Given this list of marker genes CD160, HOMER2, HIF1AN (NCBI Gene Id 84175), MEGF8, MSRB3, KDM4A (NCBI Gene Id 9682), PPFIA2 (NCBI Gene Id 8499), TIMM22, SEC22C, USP34, GID4, HTR2C, GIGYF2, TBC1D20, RGS4, RFTN1, RASAL2, FHIP2A, ZNF107 (NCBI Gene Id 7660), SH3TC2, MCTP2, ASB6, PSD3, PLD3, CCNE1, DCUN1D3, SATB2, PARP14, CNKSR2, ZDHHC16, PTPN12, FAM53C, RNF169, PRDM1, ZNF618, NAV3, PDE1B, SORT1, NR2C2, ZNF655, SLC5A3, NUP58, NSMF, BMP2K, TPR, NUFIP2, SORCS1, SLC12A5, DLGAP1, BDH1, MXI1, ARMC1, NCKAP5, NFATC1, here is a description of the gene set: from publication Chen Y, Wang X (PMID 31504780) studied in species Homo sapiens Genes predicted to be targets of miRBase v22 microRNA hsa-miR-874-3p in miRDB v6.0 with MirTarget v4 prediction scores > 80 (high confidence targets). Human Gene Set: MIR874_3P